Given this list of marker genes COPS4, COPS8, COPS7B, COPS5, COPS7A, TOR1A, COPS6, GPS1 (NCBI Gene Id 2873), COPS3, SENP8, COPS2 (COP9 signalosome subunit 2), here is a description of the gene set: The removal of a ubiquitin-like protein of the NEDD8 type from a protein. Human Gene Set: GOBP_PROTEIN_DENEDDYLATION studied in species Homo sapiens